The following is a description of a gene set: species: Mus musculus Mouse Gene Set: GOCC_MICROTUBULE_ORGANIZING_CENTER An intracellular structure that can catalyze gamma-tubulin-dependent microtubule nucleation and that can anchor microtubules by interacting with their minus ends, plus ends or sides., and this is the list of marker genes: Daw1, Rad51d, Ccdc178 (coiled coil domain containing 178), Traf5, Rilp, Agtpbp1 (ATP/GTP binding protein 1), Dcdc2a, Akap9, Mapk3, Ift74, Cd86, Ift70a1, Cep76, Ccdc15, Clic4 (NCBI Gene Id 29876), Spdl1 (spindle apparatus coiled-coil protein 1), Tubgcp2, Clip1, Hap1, Sorbs1, Arl13b, Tppp, Tcea2, Cfap206, Nr3c1, Ubxn6, Agbl4, Cep120, Kif2b, Zfyve26, Mapre3, Hspa1a, Ndn, Mapk15, Ush1g, Map4, Ddhd2, Naa40, Snap29, Csnk1d, Utrn, Ccdc85b, Usp2, Kifc3, Rilpl1, Ttll12, Gli1, Poc1a, Nphp4, Trip4, Cep57, Cfap100, Cfap20, Smo, Birc6 (baculoviral IAP repeat-containing 6), Azin1, Tpgs2, Ist1, Rp2, Mapre2, Itgb1bp1, Arhgap35, Dynlrb2, Wrn, Nudcd2, Cep68, Usp20, Lck (NCBI Gene Id 16818), Cep295nl, Tekt2, Pde4dip, Ccdc146, Spag5, Tmem67, Neurl4, Ttbk2, Ppp4r2, Hoxb4, Nek8, Rock1, Khdc3, Ubn1, Dpf2, Rab28, Rtraf, Tubgcp5, Bicd1, Rabl2, Spast, Zfp330, Map7d2, Nlrc3, Ccdc124, Bbs4, Katna1, Kif18a, Krt18 (NCBI Gene Id 16668), Ezr, Ndrg1 (NCBI Gene Id 17990), Bcas2, Lats2, Cep126, Micall1, Pdcd6ip, Ccdc42, Ranbp9, Ccnd1, Usp9x, Hspa1b, Chd3, Nlrc5, Aldob, Ift52, Cep57l1, Ttll7, Rab8a, Rab11fip5, Haus4, Pcm1, Odf2, Kif2a, Pcnt, Egfr, Cpeb1, Bccip, D7Ertd443e, Prkcb, Ccnd3, Ppp4r4, Ercc6l2, Ilrun, Cep131, Gnai2, Fbxo31, Nup62, Dync2li1, Fam234b, Adcy9, Evi5, Katnbl1, Fbxl7, Ssx2ip, Ahi1, Dctn1, Rita1, Cir1 (NCBI Gene Id 74817), Rassf7, Katnip, Tek, Katnal1, Nek4, Mkks, Frmd8, Cchcr1, Ift70b, Ocrl, Bcl3, Rap1gap2, Aunip, Fam110c, Arfgef2, Kmt5b, Sclt1, Axdnd1, Ccdc38 (coiled-coil domain containing 38), Tube1, Pibf1, Atp6v0d1, Cntrob, Katnb1, Ccsap, Chmp1a, Mllt11, Cluap1, Filip1l, Abraxas2, Limk2, Cdc42bpg, Ppp1r35, Dcaf1, Ccp110, Espl1, Alpk1 (alpha-kinase 1), Ppp1r42, Kat2b, Mlph, Cenatac, Dclre1b, Nup93, Tchp, Eef1akmt3, Enkd1, Il4ra, Topors, Pcgf5, Wdr13, Ccnb1, Ak6, Cep170, Dnaaf4, Pla2g3, Fance, Lzts2, Pax2, Kat2a, Smad7, Abcc3, Stk3, Ankrd7, Prkca, Mns1, Macroh2a1, Birc7, Sting1, Calm1, Rab34, Ift22, Tubgcp3, Spmip4, Ajuba, Mamld1, Tubg2, Phf1, Cep135 (centrosomal protein 135), Kif2c, Ccdc116, Relb, Nsfl1c, Odad3 (outer dynein arm docking complex subunit 3), Usp33, Actr1b, Bicdl1, Tssk2, Tpgs1, Ift172, Knstrn, Csnk1a1, Ccnb1-ps, Top2a, Zbed6, Ppp4r3b, Ftcd, Flcn, Tesk1, Mical1, Gas2l2, Mapre1, Ffar4, Map3k11 (mitogen-activated protein kinase kinase kinase 11), Dynlt2b, Gnai3, Poc5, Bnip2, Dyrk3, Dcdc2c, Ttll4, Dynlrb1, Pafah1b1, Pak1, Usp50, Atf5, Nfs1, Ruvbl1, Rbm39, Cdkn1b, Cep43, Plk5, Wdr35, Uxt, Ola1, Rapgef6, Map7d1, Drd4, Ccdc65, Ndc80, Git1, Cfap298, Mme, Dysf, Gas8, Dtl, Ptpn20, Dapk3, Ccnf, Ranbp1, Camsap2, Marcks, Dynll1, Sncg (synuclein, gamma), Bub1b, Fry, Disc1, Atxn10, Cfap410, Cplane2, Dctn2, Cfap96 (cilia and flagella associated protein 96), Rnf19a, Cfap126 (NCBI Gene Id 98636), Pclaf, Haus5, Saxo1, Cep85, Ppp4r3a, Ofd1, Cdk5rap3, Adrb2, Bbs9, D1Pas1, Ift56, Fez1, Myo18a, Aspm, Skp1, Ccdc28b, Agbl2, Ccdc88c, Daam1, Cct5, Brsk1, Pcna, Glg1, Cep41, Ssna1, Ska1, Mad1l1, H2ax, Ppp2r3c, Tmem201, Mecp2, Gli2, Map2k1, Nek6, Upf3b, Rttn, Dcdc2b, Rab3ip, Hook3, Cct4, Klhl4, Sfr1, Irs1, Tex9, Stx1b, Cep19, Pde4d, Cep162, Trim32 (tripartite motif-containing 32), Cdc20, Cntln, Kif3b, Cfap90, Cep152 (NCBI Gene Id 99100), Slain2, Spatc1l, Rab6a, B9d2, Dctn4, Tbc1d7, Cdk10, Bicd2, Septin1, Itsn2, Cetn1, Cibar2, Eps8l2, Bbof1, Cul7, Dync2i2, Dctn6, Ttll11, Mpp1, Tbc1d31, Ubxn2b, Cdk1, Sdccag8 (NCBI Gene Id 76816), Capn7, Hmbox1, Mzt2, Vps4b, Slc18a2, Proser3, Klhl22, Lats1, Hook2, Cabcoco1, Nme7, Ccdc22, Rab11fip3, Iqcd, Cenpf, Kif11, Zmynd10, Atf4, Ninl, Kif17, Akt3, Mid1 (midline 1), Ska3, Htt, Dennd1c, Zfp322a, Psen1, Eml4, Cep290, Mark4, Cntrl, Spatc1, Rlbp1, Psen2, Tm9sf2, Ift81, Efhc1, Snx10, Calml3, Lrif1, Gpr174, Ccdc112, Ubr4, Zfyve19, Xrcc2, Prkar2a, Nckap5l, Washc1, Hook1, Mcm3, Ccnjl (cyclin J-like), Cdk6, Pdzd2, Odf2l, Ttc8, Ruvbl2, Nin, Kifap3, Nit2, Tedc1 (tubulin epsilon and delta complex 1), Ypel5, Cdkl2, Cdc27, Ift46, Apc, Ddx3x (DEAD box helicase 3, X-linked), 4933427D14Rik, Vcp, Erc1, Ccdc18, Calm3, Cep350, Mastl, Bod1, Asap1, Ctnnbl1, Naa12, Rpgrip1l, Capg, Luzp1, Tedc2, Pkd2, Zfp365, Trim69, Prkar1a, Kif23, Pard6a, Lrp1, Cfap70, Atp6v1d, Nfe2l2 (nuclear factor, erythroid derived 2, like 2), Scyl1, Dync1li2, Iqcb1, Dlgap5, Smg6, Agbl3, Dbh, 1700012B09Rik, Cep295, Exoc4, Diaph3, Haus3, Chek1, Tbc1d30, Cep85l, Ccdc92, Chodl, Plk3, G6pd2, Nlrp3, Tubgcp4, Fbxl13, Mphosph9, Nme1, Hepacam2, Rapsn, Pfdn1, Ttll6, Ndel1, Actr8, Rabep2, Kif5b, Cdk2, Magi2, Dlg5, Cdk5rap2, Herc2, Kifc1, Fam161a, Ccdc88a (NCBI Gene Id 77927), Hyls1, Prkcq, Dhx9, Ccna2, Dync1li1, Ccne1, Ift122, Hormad2, Intu, Acaa2, Dzip1, Ift80, Specc1l, Tacc2, Tnks, Pde4b, Cspp1, Slc8a3, Clic5, Lrwd1, Ppp2r5a, Cdc42, Gabarapl1, Arl2bp, Psma1, Kif3a, Tap1, Dync1i2, Tmem63a, Crocc, Axin2, Nedd1, G6pdx, Nubp1, Haus8, Nde1, Tsga10, Braf, Gpsm2, Akt1, Fam184a, Tnks2, Smad6, Evc, Hmmr, Ythdf2, Chd4, Nudt21, Efhc2 (EF-hand domain (C-terminal) containing 2), Pik3r5, Rrm1, Rrp7a, Hnmt, Nup85, Id1, Ttc12, Mlf1, Tubgcp6, Slf1, Actr1a, Bbs2, Myof, Ift140, Mplkipl1, Rpap3, Pskh1, Haus6, Cdh23, Tubd1 (tubulin, delta 1), Lrrk2, Yes1, Apex1, Cracr2a, Pola2, C2cd5, Tubg1, Zfp12, Cys1, Cep20, Aurkb, Ckap2, Ccno, Sppl2b, Pik3r4 (phosphoinositide-3-kinase regulatory subunit 4), Smad3, Mzt1, Prkacb, Spaca9, Tsg101, Pxk, Kif24, Arl2, Sac3d1, Leo1, Dctn5, Dzank1, Plk1, Map1s, Ift57, Eif3a, Tacc1, Plk2, Lca5, Mfap1a, Ppp1r12a, Ift20, Gle1, Uvrag, Ric8b, Entr1, Psmb4, Aurka (NCBI Gene Id 99385), Hdac6, Rbbp6, Ttc28, Vps37a, Haus7, Stard9, Prkaa2, Gnai1, Psme3, Spata7, Fam110a, Tent5c, Wdr11, Sass6, Ddx11, Rassf10, Bcl2l1 (NCBI Gene Id 12048), Stap1, Mdm2, Ccdc57, Brca1, Polr3h, Rragd, Specc1, Dnajb3, Cimap3, Ecpas, Fbf1, Pkn2, Lrrc49, Kif7, Ski, Caprin2, Ccdc77, Rock2, Togaram1, Ccdc120, Bag3, Poc1b, Tacc3, Pacsin2, Map10, Hipk1, Cep112, Fsd1, Ran, Cfap53, Ttll1, Jtb, Rac1, Tsen2, Gsk3b, Ccdc141, Kif12, Gen1, Harbi1, Vps4a, Rilpl2, Cep97, Wrap73, Cd2ap, Ccna1, Tsks, Nubp2, Odf1, Cilk1, Itgb6, Cetn3, Bbs5, Dzip1l, Rpp25, Rgcc, Rabgap1, Mdm1, Nedd9, Tuba3a, Prkaa1, Dcaf12, Tcp1, Lrrcc1, Ttll2, Patj, Bud31, Ccdc66, Anks1b, C2cd3, Cdc25b, Spice1, Ccdc13, Ppp1cc, Cep192, Cep63, Topbp1, Mplkip, Ilk, Podxl, Plekha7, Atf6b, Rab23, Cep44, Cetn4, Dnaaf2, Marchf7, Ttll13, Ctdp1, Gpaa1, Ccdc88b, Akna, Keap1, Cep128, Dis3l, Cul3, Ctsc, Triobp, Trappc14, Mfap1b, Il1rn, Jade1, Eya3, Ptpn23, Cep250, Acads, Obsl1, Ttll9, Calm2, Emd, Hras, Als2, Rabl6, Spag9, Fam110b, Brca2, Misp, Psmb5, Clasp1, Irag2, Mak, 2700049A03Rik, Slc1a4, Mdh1, Kif20b, Stk11, Ush2a, Creb1, Nek2, Cibar1, Mks1, Flii, Abca2, Ttc39a, Diaph1, Tbcd, Plekhg6, Ckap2l, Naa11, Hk2 (NCBI Gene Id 15277), Rab6b, Ttll5, Nek7, Rps7, Cfap58, Tapt1, Rad51, Fign, Crocc2, Prpf6, Kmt2e, Cdc16 (NCBI Gene Id 72610), Alms1, Cyth4 (NCBI Gene Id 72318), Pqbp1, Tmub1, Serinc5, Ak5, Ift43, Cetn2, Smad4, Npm1, Dnm2, Cep83, Ccne2, Nr0b1, Ttc23l, Cfap144, Camsap3, Bloc1s2, Arhgef7, Haus1, Cep72 (NCBI Gene Id 74470), Mvb12a, Cstpp1, Steep1, Aurkc, Cyld, Tsc1, Haspin, Parp3, Fank1, Trp53, Hsf1, Atm, Mcph1, Brsk2, Fbxw8, Slc16a1, Ccdc61, Prkaca, Fnip2, Dyrk1a, Procr, Spag8, Sema4d, Deup1, Ctnnb1, Etl4, Armc9, Ccdc96, Arhgef10, Tiam1, Tulp3, Cep164, Ccdc187, Plk4, Ska2, Lhcgr, Klhl12, Cc2d1a, Ift88, Atf3, Mapk1, Nme3, Cep104, Cct8, Cadps2, Unc119, Ccdc68, Rgs14, Aaas, Prkar2b, Dtx4 (NCBI Gene Id 207521), Cep95, Pdzd7, Kif13a, Cep70, Cimip2a, Whrn, Grb2, Wdr90, Ppp4c, Fzd6, Kiz, Slmap, Prkcz, Ptk2, Stil, Dync1h1, Sfi1, Ankrd26, Kncn, B9d1, Plag1, Arl3, Cenpj, Ccnb2, Dync2i1, S100b, Ivl, Pkhd1 (polycystic kidney and hepatic disease 1), Ccdc78, Ift25, Ccdc113, Spout1, Taf1d, Trat1, Ift27, Chrm2, Cfap157, Psmc4, Cdc14a, Dynll2, Rpgr, Fbxw11, Exoc7, Kifc5b, Txndc9, Lrrc45, Camk2b, Orc2, Rad18, E2f1, Tgif2, Crmp1, Ccnj, Saxo2, Cdc45, Clasp2, Dnai1, Mtus2, Ccdc8, Bbs7, Dcaf13, Slc25a54, Haus2, Wdr62, Flot1, Ccdc81, Birc5, Atp2b4, Hnrnpu, Dynlt4, Nek1, Neil1, Nek9, Mib1 (NCBI Gene Id 225164), Cep78, Mapkapk2, Bbs1, Cdkl5, Cenpu, Cep55, Rab11a, Ccdc14, Keg1, Cep89, Dctn3, Cby1, Ckap5, Sirt2, Tbccd1, Rassf1, Sgo1, Traf3ip1, Ccnd2, Pja2, Stox1, Cib1, Numa1